Given this list of marker genes SLC8A2, BEST2, CLASP2, CD38, SLC4A7, SLCO3A1, MYO1D, ANXA13, TEK, SLC5A6, GPIHBP1, ADCY8, SLC4A8, BSG, SLC43A3, DSP, ATP7A, SLC47A1, SLC22A4, LIN7B, EPCAM, KCNQ4, CALHM3, CASK, LEPR, EPB41, AQP2, B4GALT1, CHRM3 (NCBI Gene Id 654136), ITGA9, ADRA2A, MTTP, SLC22A6, ERBB4, FLOT1, MLC1, ABCC1, CNNM2, SLC51A, CLCA2, CAV1, HEPH, SHROOM4, NUMB (NCBI Gene Id 94910), MEGF11, STXBP3, SCN3A, ABCC6, SLC13A3, RAB17, SLC27A5 (solute carrier family 27 member 5), SLC39A14, PHLDB1, ABCB11, SLC4A2, SLCO2B1, DSTYK, ATP2B2, CA9, SLC22A8, NAIP, FXYD4, AQP10, MYO1C, SLC3A2, ABCC10, SVOP, TRPC4, CEACAM1, KCNC2, C5AR2, TSHR, SLC30A1, VANGL2, BSND, SPEF1, SLC16A1, SLCO1B3, HSP90AA1, AQP1, SLC14A1, DLG3, PALM, SLCO4C1, SLC16A12, ATP2B1, ST14, SLC6A12 (NCBI Gene Id 6539), BMPR2, SLC22A11, SLC41A1, SLC31A1, STK39, ERBIN, CD44, CDH17, OTOF, P2RY1, SLC27A1, SLCO5A1, SLC22A3, ADORA1, SLCO1C1, SLC11A2 (NCBI Gene Id 4891), SLC17A5, ERBB2, VSIG1, PLEKHG4B, PDZD11, ABCC5, INPPL1, SLC38A1, CNNM4, FLOT2, SLC23A2, FXYD2, DST, SLCO1B7, SLC26A11, NKD2, SLC4A10, TF, KCNQ1, CLASP1, MSN, SLC16A3, DLG2, CLRN1, PLPP3, NDRG4, SCTR (secretin receptor), ATP1A1, FXYD5, CA12, CTNNA2, LRRC7, ATP7B, SLC22A2, SLC9A1, ANK1, LIN7C, SLC26A7 (solute carrier family 26 member 7), CADM1 (NCBI Gene Id 337934), MAP7, KCNE3, AP2A1, AQP7B, RHBG (NCBI Gene Id 57127), CD81, SLC39A5, SLC4A1, SLC19A1, ANK2, SLC4A9, CASR, SLC22A9, SLC7A7, CD34, SLC5A3 (solute carrier family 5 member 3), SLC1A3, SLC23A1, SLCO4A1, SLC7A1, ADCY10, SLC22A1, SLC12A2, LRP1, ATP6V0A4, TLR9, DIO1, STX2, GKN2, PRCP, SLC40A1, IDE, NOD1, STX4, KRT14, SLC38A3, SLC7A5, LIN7A, EPS15, SLC22A7, CD1D, SLC43A2, PIANP, CXADR, ATP1B1, CD300LG, SLC2A1, SLC16A10, KCNJ16, ABCC3, CLDN17, CLCN2, SLC2A9, ANXA1, TACSTD2, OSCP1, MYO1A, RHCG, AJAP1, SLC29A4, CA11, ABCA8 (ATP binding cassette subfamily A member 8), CLCNKB, SLC26A6, PHLDB2 (pleckstrin homology like domain family B member 2), PDPN, SLC29A2, SLC29A1, SLC6A13, SLC16A8, ANXA2, NEDD9, CLDN11, SLC1A5, ABCA1, AQP5, KCNJ4, HFE, FAP, SLC39A8, CDH2, ATP2C2, MET, SLC4A5, CA4, SLC6A6, SLC26A5, SLCO6A1, AURKA, SLC16A6, ITGA1, SCRIB, ABCC4, EDN1, HCN1, SLC16A7, MUC20, ORAI1, CLDN7, SLC7A8, LPO (lactoperoxidase), SLCO2A1, CDH16, CLDN4, FOLR1 (folate receptor alpha), NOD2, DOCK7, WASF2, CLDN8, SLC16A5, ITGA2, CALHM1, SLC46A1, TGFA, KCNJ10, LDLR, ATP2B4, GM2A, TGFBR3, HOMER3, SLC6A9, DTNB, CLDN19, AQP9, DAG1, S100G, AQP7, SLC22A5, CTNNB1 (catenin beta 1), SLC9B2, SLC51B, UMOD, SLC4A11 (NCBI Gene Id 9574), SLC9A4, SLCO1A2, CEACAM5, TJP1, SLC4A4, CA14, MAP4K2, HPGD, ATP1B3, TFRC, SLC26A1, PDGFB (NCBI Gene Id 5155), ANK3, PKD1, AQP3, DLG1, SLCO1B3-SLCO1B7, FRMPD2, AQP4, ITGB4, PTPRQ, EPPK1, PTH1R, SLC12A6, ATP12A, EZR, ITGA3, PKD2, CLCNKA, SLCO1B1, CLDN1, ENPP1, AQP8, ALPK2, MARVELD2, SLC10A1, ERBB3, BEST1, LDLRAP1, IQGAP1, C5AR1, EGFR (NCBI Gene Id 1956), ATP6V1B1, PROM2, here is a description of the gene set: The region of a cell situated near the base. For example, in a polarized epithelial cell, the basal surface rests on the basal lamina that separates the epithelium from other tissue. species: Homo sapiens Human Gene Set: GOCC_BASAL_PART_OF_CELL